The following is a description of a gene set: Human Gene Set: CUI_DEVELOPING_HEART_COMPACT_ATRIAL_CARDIOMYOCYTE studied in species Homo sapiens from publication Cui Y, Zheng Y, Liu X, Yan L, Fan X, Yong J, Hu Y, Dong J, Li Q, Wu X, Gao S, Li J, Wen L, Qiao J, Tang F (PMID 30759401), and this is the list of marker genes: RPL27A, MB, RPL7, RPS27, YBX1, FTH1, GAPDH, CRYAB, RPL31, RPS3A, COX7A1, RPL13, RPL18A, PLN, FTL (NCBI Gene Id 93315)